Given this list of marker genes Il36g, Cflar, Cxcl10, Stat1, Tmem182, Rapgef3, Nfe2, here is a description of the gene set: Any process that decreases the frequency, rate or extent of the formation of a syncytium, a mass of cytoplasm containing several nuclei enclosed within a single plasma membrane, by the fusion of the plasma membranes of two or more individual cells. Mouse Gene Set: GOBP_NEGATIVE_REGULATION_OF_SYNCYTIUM_FORMATION_BY_PLASMA_MEMBRANE_FUSION studied in species Mus musculus